The following is a description of a gene set: Mouse Gene Set: GOBP_GUANINE_METABOLIC_PROCESS The chemical reactions and pathways involving guanine, 2-amino-6-hydroxypurine, a purine that is one of the five main bases found in nucleic acids and a component of a number of phosphorylated guanosine derivatives whose metabolic or regulatory functions are important. studied in species Mus musculus, and this is the list of marker genes: Urah, Nt5c2, Hprt1, Kdm1a, Uox, Gda, Xdh, Urad, Pnp